The following is a description of a gene set: Human Gene Set: WP_GLIOBLASTOMA_SIGNALING Glioblastoma signaling species: Homo sapiens, and this is the list of marker genes: CDKN1A (NCBI Gene Id 1026), MDM4, FGFR1 (NCBI Gene Id 84151), PIK3R2, CCND1, CDK4, PDGFRA, CDKN1B, PLCG1, MAP2K5, FOXO3, CDKN2C, PLCG2, PRKCQ, RB1, AKT3, TSC2, GAB1, FOXO1, MAP2K6, PRKCA, PRKCZ, RAF1, PRKCI, PRKCG, ERBB3, PRKCH, PIK3C2A, ATM, CCNE1, MIR21, MAP2K4, MAPK1, ERRFI1, TP53, TSC1, MAP2K2, MET, CDK2, MSH6, EGFR, MAPK3, FGFR2 (fibroblast growth factor receptor 2), PIK3R1 (phosphoinositide-3-kinase regulatory subunit 1), KRAS, IGF1R, E2F1, AKT1, NF1, PTEN, FOXO4, MDM2, BRCA1, ERBB2, PDPK1, IRS1, CBL, EP300, PIK3C2B, PIK3CD, PRKCB, BRAF, NRAS, PIK3CG, CDKN2B, PIK3CB, BRCA2, PDGFRB, CDKN2A, PIK3C2G, AKT2, ARAF, SPRY2, PIK3CA, CDK6, PRKCD, CCND2, MAP2K1, GRB2, MAP2K7, HRAS, SRC, MAP2K3